Given this list of marker genes TNF, MDK, HPN, TNFAIP3, WNT3A, XBP1, RTN4, PTN, MED1, CFLAR, here is a description of the gene set: Any process that activates or increases the frequency, rate or extent of hepatocyte proliferation. Human Gene Set: GOBP_POSITIVE_REGULATION_OF_HEPATOCYTE_PROLIFERATION studied in species Homo sapiens